The following is a description of a gene set: Human Gene Set: GOBP_POSITIVE_REGULATION_OF_HIGH_DENSITY_LIPOPROTEIN_PARTICLE_CLEARANCE Any process that increases the rate, frequency or extent of high-density lipoprotein particle clearance. High-density lipoprotein particle clearance is the process in which a high-density lipoprotein particle is removed from the blood via receptor-mediated endocytosis and its constituent parts degraded. studied in species Homo sapiens, and this is the list of marker genes: GPLD1, MIR33A, MIR302A, MIR144, TREM2, LIPG, MIR33B (microRNA 33b)